The following is a description of a gene set: Binding to a gamma-aminobutyric acid (GABA, 4-aminobutyrate) receptor. studied in species Mus musculus Mouse Gene Set: GOMF_GABA_RECEPTOR_BINDING, and this is the list of marker genes: Trak2 (NCBI Gene Id 98647), Gabrb1, Erbb4, Maf1, Gabrg1, Gabarap, Akap5, Lhfpl4, Clptm1, Gabarapl1, Arfgef2, Plcl2, Shisa7, Gabra5, Ppp2ca, Trak1, Plcl1, Jakmip1